The following is a description of a gene set: Human Gene Set: ZNF41_TARGET_GENES Genes containing one or more binding sites for (ZNF41) in their promoter regions (TSS -1000,+100 bp) as identified by GTRD version 20.06 ChIP-seq harmonization. from publication Yevshin I, Sharipov R, Kolmykov S, Kondrakhin Y, Kolpakov F (PMID 30445619) studied in species Homo sapiens, and this is the list of marker genes: CYP17A1, EXTL3, RALGAPA2, IQSEC1, HEXD, PARVA, DCLK1, NCLN, FRAS1, NFIA, SYNPO2, IQCF4P, MIR888, SHISA3, PIGL, KDR, NSL1, SOX2-OT, SEC22B, SLC35B1, LINC01224, GSTCD, MTND5P11, GTDC1, CHEK2P2, RPL9P32, SCGB1D2, MIR1302-3, IFT46, RANGAP1, COX4I1P1, PMS2P4, TLCD1, PPP1R1A, FCF1P6, DST, TARS2, SPTSSB, DDX11, ITPR1-DT, MAPK8IP3, LINC02547, FCF1P1, NIPA2P5, FMN1, CD63, EPCAM, SLC24A1, SDCCAG8, CARD8-AS1, NEURL2, PDGFD, GRAMD1B, THSD4, KRT40, PSG4, INTS9, ZDHHC19, RBFOX3, ATXN7L1, MIR99AHG, GNG4 (NCBI Gene Id 2786), CIAO2A, BROX, TLE6, DIPK2A, STXBP5L, ADAP2, GPR85, POMT2, R3HCC1, FAF1, WDR11, SYCP2L, TRIP4, LMF1, COA1, PDCD4, JPX, UTP6, NFIC, LRRC40, RBMS3, UBXN7-AS1, EIF4EBP2, MPP7-DT, PANK2-AS1, GNA15-DT, PNLDC1, MIR5687, LRRC41, TRDMT1, TNFAIP8L3, GUSBP18, PA2G4, TBP, AK2, EXOC7 (exocyst complex component 7), PCLAF, S100A4, DTWD1, RABGAP1L, ZNF221, ZBTB11, DDX23, CDHR3, MUTYH, SLC16A9, LIPE, ZNF354B, XBP1P1, JCAD, ENSG00000257997, PANTR1, EPCAM-DT, RUNDC3A, CTSK, S100A3, ARHGEF1, INTS12, WDR11-DT, HMBOX1, IGF1R, RAB42P1, RFX7, SLFNL1, POLR1A, ATP2B4, FCF1P7, HDAC5, FCF1P2, GLA, COP1, CCM2, COL14A1, RSPH3, COL4A5, TPD52, TCF7L2, AIDA, IMPDH1, BCL7A, PLD2, NDUFB2, CFAP74, U2AF2, CHRM3 (NCBI Gene Id 654136), CACNA1A, PROCA1, TATDN3, ZNF609, RPL13AP16, SRSF11, PANK2 (pantothenate kinase 2), CADPS, FCF1P8, DTD1, FAM227B, TMEM62, ENSG00000215156, TTLL9, RNF44, EFCAB7, MICB, FCGRT, COPDA1, HNRNPH2, ENSG00000259737, TAGAP-AS1, SEPTIN7-DT, CDKN2C, SCAF8, ENSG00000268129, KIAA1217, PSMD2, ST6GALNAC4, RBMS3-AS3, ITGB3BP, OMA1, NORAD (NCBI Gene Id 647979), DAB1, TEFM, ENSG00000248576 (novel transcript, antisense to SMUG1), ZNF155, RABGAP1L-DT, DR1, CARD8, EFNA5, MTCO3P12, LINC01739, BIRC6, CASTOR3P, SMIM26, MPV17L2P1, ITPR1, RNU6ATAC34P, SLC25A24, TEF, TMT1B, DSTYK, GFY (golgi associated olfactory signaling regulator), MECOM, UCK1 (uridine-cytidine kinase 1), DUSP15 (dual specificity phosphatase 15), INTS14, COL4A6, RPA3, FAM201A, BRME1, MDGA1, AKAP1, CDC14A (NCBI Gene Id 8556), PTCD3, PRKAG2-AS2, CTSA, SERBP1, XPNPEP1, SEC14L1, GRIP1, SLC11A2, ZNF765, AREL1, AK5, FCRLA, RIOK3, UBE2M, HCG20, RABGAP1L-AS1, RNA5SP194, IPO4, SLC27A5, SEPTIN7, SLC39A1, SNX1, ZSCAN16-AS1, AOC1, GAS7, G2E3, STAG3L4, TRERNA1, AZIN2 (NCBI Gene Id 113451), ZNF391, SF3B5, U2SURP, SUCLG1